The following is a description of a gene set: We have analyzed the developmental molecular programs of the mouse hippocampus, a cortical structure critical for learning and memory, by means of large-scale DNA microarray techniques. Of genes and expressed sequence tags examined, 1,926 showed dynamic changes during hippocampal development from embryonic day 16 to postnatal day 30. Gene-cluster analysis was used to group these genes into 16 distinct clusters with striking patterns that appear to correlate with major developmental hallmarks and cellular events. These include genes involved in neuronal proliferation, differentiation, and synapse formation. A complete list of the transcriptional changes has been compiled into a comprehensive gene profile database (http://BrainGenomics.Princeton.edu), which should prove valuable in advancing our understanding of the molecular and genetic programs underlying both the development and the functions of the mammalian brain. Genes highly expressed in prenatal hippocampus (cluster 1). from publication Mody M, Cao Y, Cui Z, Tay KY, Shyong A, Shimizu E, Pham K, Schultz P, Welsh D, Tsien JZ (PMID 11438693) species: Mus musculus Human Gene Set: MODY_HIPPOCAMPUS_PRENATAL, and this is the list of marker genes: RPS27, RPS8, RPL9, CDK2AP1, HNRNPA0, NEUROG2, SRSF6, CCNG2, RPL34, EFTUD2, UBE2C, POLR1C, CCNB2, RPL13, RPL37, NFYB, RPL13A, LSM4, H2AZ2, CKS2, RPL23A, PCNA, TP53, EIF4A3, BTF3, CCND2, H2AC8, RPL12, CDK4, RPL30, TOP2A, RBPJ, H2AX, MYT1, EIF2S2, H1-0, WBP1, RPL8, EEF1G, RPS18, SNRPB2, RPL19, GADD45G, DDX19A